Given this list of marker genes Chsy3, Chsy1, Csgalnact1, B4galnt3, Chpf2 (chondroitin polymerizing factor 2), B4galnt4, Csgalnact2, Chpf, here is a description of the gene set: Mouse Gene Set: GOMF_GLUCURONOSYL_N_ACETYLGALACTOSAMINYL_PROTEOGLYCAN_4_BETA_N_ACETYLGALACTOSAMINYLTRANSFERASE_ACTIVITY species: Mus musculus Catalysis of the reaction: D-glucuronyl-N-acetyl-1,3-beta-D-galactosaminylproteoglycan + UDP-N-acetylgalactosamine = N-acetyl-D-galactosaminyl-1,4-beta-D-glucuronyl-N-acetyl-1,3-beta-D-galactosaminylproteoglycan + UDP.